Given this list of marker genes P3H3, P3H2, P4HA2, P4HA3, P4HA1, P4HB, P3H1, P4HTM, here is a description of the gene set: Catalysis of the reaction: procollagen L-proline + 2-oxoglutarate + O2 = procollagen trans-hydroxy-L-proline + succinate + CO2. Human Gene Set: GOMF_PROCOLLAGEN_PROLINE_DIOXYGENASE_ACTIVITY studied in species Homo sapiens